The following is a description of a gene set: The component of the postsynaptic specialization membrane consisting of gene products and protein complexes that are loosely bound to one of its surfaces, but not integrated into the hydrophobic region. Human Gene Set: GOCC_EXTRINSIC_COMPONENT_OF_POSTSYNAPTIC_SPECIALIZATION_MEMBRANE studied in species Homo sapiens, and this is the list of marker genes: SCRIB, CNKSR2, RNF10, FGF22, AKAP9